The following is a description of a gene set: A T cell apoptotic process that occurs towards the end of the expansion phase following the initial activation of mature T cells by antigen and is triggered by T cell receptor stimulation and signals transmitted via various surface-expressed members of the TNF receptor family such as Fas ligand, Fas, and TNF and the p55 and p75 TNF receptors. species: Mus musculus Mouse Gene Set: GOBP_ACTIVATION_INDUCED_CELL_DEATH_OF_T_CELLS, and this is the list of marker genes: Il2ra, Fas, Akt1, Cd47, Tnfsf4, Rps6, Tgfb2 (transforming growth factor, beta 2), Dnaja3 (DnaJ heat shock protein family (Hsp40) member A3), Fadd, Ripk3, Tnfrsf4, Gpam, Tsc22d3, Siva1